Given this list of marker genes IFNG (interferon gamma), PKHD1, PAX2, PBX1, INVS, H4C3, TSC2, here is a description of the gene set: species: Homo sapiens A lack of differentiation between renal cortex and medulla on diagnostic imaging. Absence of renal corticomedullary differentiation Human Gene Set: HP_ABSENCE_OF_RENAL_CORTICOMEDULLARY_DIFFERENTIATION